The following is a description of a gene set: Human Gene Set: MIR10398_3P from publication Chen Y, Wang X (PMID 31504780) species: Homo sapiens Genes predicted to be targets of miRBase v22 microRNA hsa-miR-10398-3p in miRDB v6.0 with MirTarget v4 prediction scores > 80 (high confidence targets)., and this is the list of marker genes: KLLN, TEX35 (NCBI Gene Id 84066), RBM14-RBM4, TFAP2A, RBM4